The following is a description of a gene set: species: Homo sapiens Degradation of beta-catenin by the destruction complex Human Gene Set: REACTOME_DEGRADATION_OF_BETA_CATENIN_BY_THE_DESTRUCTION_COMPLEX, and this is the list of marker genes: CTBP1 (C-terminal binding protein 1), PSMD3 (NCBI Gene Id 94019), CTBP2, CSNK1A1, SKP1, PSMA3, TLE3, AXIN1, PSMC2, PPP2CB, PSMA4, PSMC3 (proteasome 26S subunit, ATPase 3), TLE1, PSMD6, TLE2, PPP2R1B, PSMD7, UBB, APC, TLE4, PSMB5, GSK3B, MYC, PSMD8, AMER1, PSMB4, ADRM1, CUL1, TCF7L1, PSMD12, TLE5, UBA52, PSMC5, PPP2R5C, ZRANB1, BTRC, PSMA2, FRAT2, PSMB6, PPP2R1A, PSMB3, PPP2R5B, PSMC1, FRAT1, PPP2R5D, PSMD1, PSMC6, RPS27A (NCBI Gene Id 6233), PSMB1, PPP2R5E, PSMD11, PPP2R5A, PSMC4, PPP2CA, SEM1, UBC, PSMA5 (proteasome 20S subunit alpha 5), LEF1, PSMA1, PSMA7, CTNNB1, PSMD2, PSMA6, RBX1 (NCBI Gene Id 9978), AXIN2, HDAC1, PSMD13, TCF7L2, PSMD14, PSMB7, PSMB2, TCF7